Given this list of marker genes Adig, Ccdc80, Bckdhb, Ghr, Col6a3, Cxcl12, Ppp2r5a, Fez2, Bnip2, Sult1a1 (sulfotransferase family 1A, phenol-preferring, member 1), Dhrs7, Idh1, St3gal6, Pgm1, Ahnak, Man1a, Lum, Qki, H6pd, Plac8, Col3a1, Sorbs1, Srpx, Decr1, Sqor, Acaa1a (NCBI Gene Id 52057), Vwf, Lamb1, Thbd, Col5a1, Dpep1, Gnai1, Heph, Penk, Map4, Tgfbi, Nr1h3, Gja1, Cavin3, Alad, Zeb1, Pde8a, Fstl1, Derl1, Cd34 (CD34 antigen), Mfng, Ephx2, Adipor2, Gpam, Dpt, Nrp1, Fzd4, Col1a1, Htra1, Mrc1, Angptl2, Rab34, Col18a1, Phyh, Klf4, Cidec, Col4a1 (NCBI Gene Id 207132), Dgat1, Etfb, Gas6, Crip1, S100a6, Alas1, Hspb8, Clec3b, Uck1, Igfbp6, here is a description of the gene set: species: Mus musculus Epidemiological studies indicate that parity enhances HER2/ErbB2/Neu-induced breast tumorigenesis. Furthermore, recent studies using multiparous, ErbB2/Neu-overexpressing mouse mammary tumor virus (MMTV-Neu) mice have shown that parity induces a population of cells that are targeted for ErbB2/Neu-induced transformation. Although parity accelerates mammary tumorigenesis, the pattern of tumor development in multiparous MMTV-Neu mice remains stochastic, suggesting that additional events are required for ErbB2/Neu to cause mammary tumors. Whether such events are genetic in nature or reflective of the dynamic hormonal control of the gland that occurs with pregnancy remains unclear. We postulated that young age at pregnancy initiation or chronic trophic maintenance of mammary epithelial cells might provide a cellular environment that significantly increases susceptibility to ErbB2/Neu-induced tumorigenesis. MMTV-Neu mice that were maintained pregnant or lactating beginning at 3 weeks of age demonstrated accelerated tumorigenesis, but this process was still stochastic, indicating that early pregnancy does not provide the requisite events of tumorigenesis. However, bitransgenic mice that were generated by breeding MMTV-Neu mice with a luteinizing hormone-overexpressing mouse model of ovarian hyperstimulation developed multifocal mammary tumors in an accelerated, synchronous manner compared to virgin MMTV-Neu animals. This synchrony of tumor development in the bitransgenic mice suggests that trophic maintenance of the mammary gland provides the additional events required for tumor formation and maintains the population of cells that are targeted by ErbB2/Neu for transformation. Both the synchrony of tumor appearance and the ability to characterize a window of commitment by ovariectomy/palpation studies permitted microarray analysis to evaluate changes in gene expression over a defined timeline that spans the progression from normal to preneoplastic mammary tissue. These approaches led to identification of several candidate genes whose expression changes in the mammary gland with commitment to ErbB2/Neu-induced tumorigenesis, suggesting that they may either be regulated by ErbB2/Neu and/or contribute to tumor formation. Mouse Gene Set: LANDIS_BREAST_CANCER_PROGRESSION_DN Genes down-regulated in preneoplastic mammary tissues and whose expression is maintained in tumors. from publication Landis MD, Seachrist DD, Abdul-Karim FW, Keri RA (PMID 16434967)